Given this list of marker genes THRAP3, CILP, DCTN1, CCDC102A, RPN1, SDC4, PLAC9, HDHD5 (haloacid dehalogenase like hydrolase domain containing 5), SLC35G6, P3H4, DDX23, USP7, GPR63, RCAN3, GRIP1, CCDC159, REM1, EDNRB, HCN2 (NCBI Gene Id 610), FASTK, VWA2, BCL2L15, FNDC4, C4orf33, SLC36A2, CTDP1, PNMA3, STK32A, FABP2, SUGP2, FIBCD1, FADS3, BNIP5, JTB, DPYSL3, WNT2B, TMEM63A, GJB4, ARMCX1, SIPA1L2, TPO, EI24, CCDC134, SLITRK5, IL20RB, MYO6, ATP1B1, PTH2R, MARS2, TBR1, CPT1C, PDYN, SRL (sarcalumenin), WFIKKN1, EIF3C, CGREF1, UGT2B17, GFUS, CDR2L, LRRC36, CD99L2, DSTN, IRX2, SHISA4, TAMALIN, TRIM15, GRIA2 (NCBI Gene Id 2891), OAZ1, TRIP4, NAT10, SOX5, COL16A1, ZHX3, ITPRIPL1, SAMD7, THAP7, LRCH2, MFSD6, SEPTIN3, TMEM39A, FBLN7, CYP46A1, SPON1, UNC45A, TNFSF8, EDA2R, DHH, PLIN4, PNMA5, ADCY6, FXYD2, CECR2 (NCBI Gene Id 27443), IZUMO2, NSG1, ITIH4, RPL38, ZNF341, SPTSSB, PPFIA2, RPL37, APBB3, FAM47E, HSPB1, AK1, ARPC5L, RAP1GAP2, GHRHR, UBE2QL1, SLC25A3, MAGEA11, ZBTB10, CHDH, MAP6D1, NBL1, SS18L2, EFHC1, MORN2, RUSF1, SIAH1, WNK1, CRKL, LAMA1, GPR153, NAP1L2 (NCBI Gene Id 4674), FAM217B, KCNE2, DNAJB5, FAM221B, STK39, LIN28A, F8A1, SCRN2, ATP6V0B, EFNA4, KIF21A, FAM110D, TRAF1, GNAO1, KHDRBS3, RASAL3, H3C4, ERCC6, ZNF287, POU4F3, TSPAN2, TMEM132D, FOXS1, CD34, MDGA2, ENTPD3, ICAM5, DSP, CRIP2, GFPT2, GPRIN3, UBE2J1, TPH2, ECPAS, AZIN2, PLCE1, FEM1B, TRIP6, ARHGDIG, SPNS3, NOX4, ATP6V1H, CHD4, IL1R2, MRM3, NLRP6, CDH15, SNX3, LRRCC1, CHCHD2, MUSTN1, ALDOAP2, LGI2, CACNA2D4, OR51E1, AAK1, PRKAA2, CNKSR1, MIOS, FAM25C, FAM181A, TTLL11, SNX24, PLEK2, S1PR4, CLIP4, ATP6V0C, DUSP14, PPP2R5E, LRRIQ4, TNFRSF12A, PTCRA, CRABP2, IGFBP1, SNX17, here is a description of the gene set: Genes up-regulated in bone marrow-derived macrophages at 45 min of stimulation by IL6 and LPS: wildtype versus IL10 knockout. IL-10 or IL-6 stimulation of control 129xC57BL/6 murine bone marrow derived macrophages in the presence of LPS. We used microarrays to detail the global programme of gene expression changes in response to IL-6 or IL-10 stimulation in the presence of lipopolysaccharide. BMDMs were isolated from control, IL-6-/-, and IL-10-/- mice on a 129XBL/6 mixed background mice and differentiated in the presence of CSF-1 for 6-7 days. Cells were scraped and plated in 6 well plates at 2x10e6/well. Cells were washed with complete DMEM and rested for 1-2 hr before stimulation with combinations of IL-10 (10 ng/ml), IL-6 (2 ng/ml) or LPS (100 ng/ml) for 45 min or 180 mins. Complete biological replicates were performed. Human Gene Set: GSE5589_WT_VS_IL10_KO_LPS_AND_IL6_STIM_MACROPHAGE_45MIN_UP species: Homo sapiens from publication El Kasmi KC, Holst J, Coffre M, Mielke L, de Pauw A, Lhocine N, Smith AM, Rutschman R, Kaushal D, Shen Y, Suda T, Donnelly RP, Myers MG Jr, Alexander W, Vignali DA, Watowich SS, Ernst M, Hilton DJ, Murray PJ (PMID 17114459)